The following is a description of a gene set: Human Gene Set: ZSCAN31_TARGET_GENES studied in species Homo sapiens Genes containing one or more binding sites for (ZSCAN31) in their promoter regions (TSS -1000,+100 bp) as identified by GTRD version 20.06 ChIP-seq harmonization. from publication Yevshin I, Sharipov R, Kolmykov S, Kondrakhin Y, Kolpakov F (PMID 30445619), and this is the list of marker genes: ERVK3-1, NSMCE4A, COPA, GNL3L, APIP, ANKRD42-DT, ZNF334, MAST2, TSNAX-DISC1, HTR7P1, TRIM8-DT, DNAJC25, LSR, NUP160, CCDC69, RSRC1, GIN1, BANP, GPAM, OVCA2, HILPDA-AS1, VPS51 (NCBI Gene Id 739), NUP107, RTTN, CCND2, EAF1, MRPS31, RNF122, SAMD11, ENTREP3, TAF12-DT, ZNF428, TRAF3IP1, RCAN2-DT, GRK4, BMF, TNFRSF19, CFAP74, KLHL20, CUL5, DYNC2I1, ARHGEF25, DNAJB1, GGA1, NUDT19-DT, TTBK1, SRSF2, SLX9, NBPF1, AFF4, TRMU, ITPR2, GMNN, DNAI4, UBIAD1, KAT6A, ZNF565 (zinc finger protein 565), AURKAIP1, GTF2H2C, ARPIN, SNORA8, PSTK, DUS1L, VTA1, RPS18, LINC03060, SUOX, ZAR1L, UBXN1, PHB1, KIF1C (kinesin family member 1C), NUBPL-DT, ASNS, SMIM27, PMAIP1, GNAI3, SKP2, MTFR1, SCAND3, PAK2, AMDHD1, MRPL40, NUDT19, POLR3B, B9D1, USP44, LINC02086, LRRC37A5P, WDR11-DT, DDX55, PDXDC2P, SLC25A10, SLC27A3, SUPT5H, CAST, MIR3661, PFKM, ARHGDIA, RPIA, AP3B1 (adaptor related protein complex 3 subunit beta 1), PIERCE1, AARSD1, OAZ3, NDUFAF4P1, HMOX2, ADAT2, VPS13B, LINC01098, TACO1, RCAN1, MAN2C1, COPS7B, ABCA17P, ERRFI1-DT, PIN4, REXO4, CSRNP2 (cysteine and serine rich nuclear protein 2), SRRM2-AS1 (SRRM2 antisense RNA 1), PGAM5, TRIM8, TSNAX, CCDC59, TTC23L, PPP2CA, BAZ1A-AS1, KLHL42, CAPN14, EEF1A1, NUP107-DT, NAPG, ZNF829, GIPC1, COA6-AS1, ZNF511-PRAP1, RUSF1-DT, MYO10, GOLM2, POLG, E2F4, KIF23-AS1, CDKN2C, TIGD1, ABR (NCBI Gene Id 82701), METTL6, MLEC, SPOPL, PAM16, SFT2D3, EFCAB10, TMEM147, LINC00665, PPP6R2, PGAM1P5, HNRNPL, PDE4A, SNRNP25, RFX2, ETNK1, STX6, MRPS31P4, NIPBL, CCNT1, ELP3, TACC2, SNX17, TMEM116, CCNC, PEX13, PNRC1, SLC24A1, ELL3, PDCD6P1, LARP6, STX18, UBXN2A, PAFAH1B3, DSTYK, METTL25, CNPY3, ZDHHC17, RNPEP, WDR90, PHKG2, TLL2, NPPC, EXOSC9, MCRS1, FBXW4, KIAA0319L, ZSCAN18, HSPA4, WTAP, KCNS3, MIPEP, PRDX2, COA6, INPP5B-AS1 (NCBI Gene Id 128266844), ANKFY1, AMACR, THAP1, SNRPD1, TMEM222 (transmembrane protein 222), ARID1A, RBBP5 (RB binding protein 5, histone lysine methyltransferase complex subunit), MYO9A, VPS33B-DT, KCTD7, IGHMBP2, RRP15, RAB40A, DENR, PRKAA1, PURA, ZNF721, BMS1P4-AGAP5, LRFN2, HDAC5, TMEM79, CZIB, ZNF487, ZMPSTE24, TMEM202-AS1, YIPF2, COPRS, GRB2, CADM1, NDP-AS1, DOC2A, MTF2, MTR, KCNJ2, ZMPSTE24-DT, ZNF529-AS1, NCOA4, LYRM7, HSPA5-DT, SNORA1, LBX1, ARPIN-AP3S2, ADD3-AS1, TRDMT1, USP30, PPIP5K2, DHRS4-AS1, PGM3, SLU7, STARD10, LGALS1, MRPL19, SLC25A48, C8orf88, MIR1302-3, ZNF180, LUZP1, CLK3, IBA57-DT, PRRG2 (NCBI Gene Id 5639), TMEM14A, WDR11, EXOSC6, RFNG, CES2, NCDN, BRD8, TMEM147-AS1, PLPP6, RWDD2A, ZNF544 (zinc finger protein 544), TXNDC9, SMARCC1, G6PD, MFSD6, ENO1-AS1, CCPG1, AIRIM, ESYT1, PHPT1, IFT56, ZNF490, TBCB, BACH2, EMG1, FAM98C, RAI14, INTS12, MKX, FANCD2, ADD3, TRMT61B, PEX16, ENPP4, GUSBP2, NDUFC2, HERPUD1, ZNF263, SPEN, WSCD1, C10orf143, GNPAT, LRRC49, ABCA3, RBM45, NSFL1C, USPL1, CFAP298-TCP10L, PDLIM5, UBR3, PKN2, PFKFB3-AS1, PHB2, PPP1R12C, PDXK, COPS2, UBE2V1P4, COX4I1, RPS19BP1, PDE6D, ZNF425, HIRA, MBOAT1, INO80C (INO80 complex subunit C), SLC44A1, DNM1L, DMAP1, STRA6, DNA2, C19orf12, KLRG2, MCFD2, VPS36, SUSD4, EFCAB7, INCA1, PLCD3, R3HCC1, ERMARD, CSTF2T, PDXDC1, HTR5A, DRG2, TLN1, MED25, RTKN2, SNORD6, MIR4519, LNPEP, PCBD2, PCLAF, CZIB-DT, PPP1R12B, SGK1, LIN9, PPP6R1, TXNDC12, GBA1, NT5DC3, GLIS2, CDKL2, TUBA1A, ENSG00000232995, ERP29, SDHAP3, PIGG, SNX24, ANKMY2, LINC02846, IPP (NCBI Gene Id 3652), DYNLT2, CCDC87, CABLES2, MRPL9, LINC02987, ZKSCAN2, HERC3, FEM1B, BTF3L4, SEC11A, PIP5K1B, EXOSC3, DNAJC25-GNG10, HMGB1, ETNK1-DT, CCDC38, MTF1, ZNF420, HNRNPA0, NOL9, CUL7, ANGEL1, FAAP24, RNF144B, DNAH2, ZBTB45, ATOSA (atos homolog A), PPAN (NCBI Gene Id 84997), STN1, ZNF566, MAST4, C18orf21P1, HINT3, LATS1, LINC00240, SUB1, MANEAL, EEFSEC, ENHO, TTC4, ZNF527, NDUFC2-KCTD14, FBXW11, KLHDC9, PNRC2, PRR3, ZNF747-DT, CHD9, UGCG, FZD2, BPTF, POLG-DT, IDI1, MRM2, VPS33B, LINC01547, PDE11A, MRPL58, TMEM101, CENPP, LINC02292, DCAF6, ZNF607, SRSF11, MEAK7, MTERF2 (mitochondrial transcription termination factor 2), UBE2D2, ZNF460, AKT3, ACBD6, SPHK1, TOLLIP, SLC35E1, ARHGAP45, LINC02593, C17orf75, FUZ, FOXN2, EIF5B, PHAX, ZNF260, COASY, LZTS2, RARA, SF3A3, RBM48, EME1, POU2F2, VGLL4, TAF12 (TATA-box binding protein associated factor 12), NRSN2, GPR89A, BMAL2, NAPEPLD, MOB4, PTPN20, MEMO1, FBXO4, ZNF284, CCDC77 (NCBI Gene Id 84318), KCTD13-DT, CPSF4, RMDN3, MAPK14, ENPP3, ZBED6, TDP2, RNVU1-27, CLTC, PSME3, TOLLIP-DT, NOXA1, PEX14, CFAP298, ITGB3BP, ERMP1, TAS1R1, HMGA2-AS1, ZNF461, NMNAT1, DLD, NDUFV3, ARMC2, H2BC26, ACSF2, SLC25A13, TRIP4, ETV6, REXO5, C18orf32, BRF2, ZNF223, TMED4, CMTM3, FAM133B, MYG1, NRP2, COMMD4, SYNGR2, H3-3B, EMC8, NUBPL, CAMLG, MED18, ISG20, MRS2, BMS1P4, SPTBN1, LINC00662, NIF3L1, FGFBP3, RUSF1, PTTG1 (NCBI Gene Id 9232), EHD3, PPP2CA-DT, TM2D1, SMIM8, NSL1, BBS4, SLC5A6, MAP3K21, OSBPL8, LINC01686, FNDC1-AS1, H3-3A, SLC27A5 (NCBI Gene Id 22942), CSNK2A1, MARVELD2, NDUFS7, PTDSS2, YTHDF2, ORC3, SESN2, STARD3, SOCS2, PACERR, PTPN9, CYREN, ENSG00000233461, ZNF107, ZMAT3, NOL8, NFYC, KIF23, KDM1A, KBTBD4, PPIL3, ARAP1, ZBED9-AS1, CARMIL1, GABARAPL2, PDCD2L, ACOT13, ZNF146, NOSIP, LZIC, PPAN-P2RY11, FAM98B, ENSG00000273145, CLTB (clathrin light chain B), NOP14, ALKBH3, ZNF793, ZNF511, GGT1 (gamma-glutamyltransferase 1), GALK2 (NCBI Gene Id 2585), VANGL2, BBS10, KDM5A, TNRC6A, CHD2, ELAC1, RARS2, MRPL44, PDCD5, GTPBP3, EIF1, TATDN3, MTOR, RPS7, TESHL, SETD5, GPR108, ZNF568, MIR6853, PEMT, DPP9, CAPN2, PROCA1, EIF2B4, UBE2I, NDUFAB1, DCTN2, RERE, HOXC4, ANKRD7, RNASEH2C, ADRM1, VCF2, ZER1, ANKRD42, CIDECP1, NDUFA11, INTS14, EIF2D, IMPACT, MAP2K5, RAB11A, SRP68, GLUD1P3, CCS, COPZ1, NDUFS3, LMBRD2, MTCO3P12, DNAH14, TTC23L-AS1, TANC1, NUF2, USP33, NUDT1, MANSC1, UCKL1, MIR3621, SPOPL-DT, TAF1D, SNRPB, RCAN2, SNHG5, ERI2, MPPED2, PTGS2, CFAP418-AS1, HADH, STK11, RBFOX3, IER5, RPL37, KCTD5, ERRFI1, ZMYM1, CAPNS1, IMP3, FSTL3, SNRNP200, PTCD1, ANO8, TRAPPC3, SLTM, PRKCSH, ZC3H11A, ENSG00000236846, POLR3K, CDIPTOSP, HDAC2, CALM1, METTL15, POLR2I, TMEM209, USP14, NME1-NME2, NT5C, SLC50A1, ADAM17, PPIL4, HEATR1, SLC39A7, ZDHHC4, TECR, ZC3H10, VPS26C, CDK2AP2, RAB23, ZNF780A, HMGN1, ZNF529 (NCBI Gene Id 92279), ZNF689 (NCBI Gene Id 553125), CLN3, EIF4E2, MYO3B-AS1, ZNF566-AS1, MIR6781, PRPF40B, CDIPT, AGAP3, USP22, DAZAP1, CSK, ZC3H15, GATAD1, ME2, MRPS2, SATB2, GFRA1 (GDNF family receptor alpha 1), TNFAIP8L1, DPY19L4, RPSAP69, CBLN3, SFR1, LTBP4, NABP2, LRRC40, SDHAF3, ODAD3, ZNF383, HILPDA, MRPS34, MRPL27, CCDC30, PEX3, CLPB, LOXL1-AS1, MTMR9, RN7SL521P, HDAC2-AS2, HCP5, PRSS27, MAP2K5-DT, FBXO22, AFF4-DT, NCSTN, RHOB, JMJD4, C15orf40, LINC02773, MCRIP2, BZW2, EXD3, C1orf131, MITD1, MPC2 (mitochondrial pyruvate carrier 2), ATRAID, ZNF747, TUBGCP3, C2CD2L, RPL27 (ribosomal protein L27), WRAP73, NKAPP1, RABEPK, DENND4A, HUNK, ZNF793-AS1, ZNF155, NOP16, CBX5, RPS4X, TARS2, MAP7D1, TMEM42, RPL13A, ADAP2, MIR762HG, ZNF195 (NCBI Gene Id 7748), HEATR5A, HEBP1, GINS3, CREB3, RGS5, FBXO5, MRPS23, PUS10, ASH1L, PNRC1-DT, SIRT5, GAP43, KCTD13, CSNK1E, IQGAP2, MYOCD, KIF20A, LLGL2, C12orf76, DPAGT1, SMG5, BAG3, MKRN2, TMEM186, PRRT3-AS1, MST1P2, GSTCD, CFAP20DC, IPO4, FBXO27, USP31, TMEM50B, RBPMS, SCAF4, ZSCAN31, PFKFB3, GOLPH3L, THAP10, MRPL30, NMRAL1, NUDT5, TVP23B, SURF6, LRP6 (LDL receptor related protein 6), TATDN2, ASAH2B (NCBI Gene Id 653308), FGF9, PGGT1B, TRAM2, TMEM242, TLCD2, RN7SL2, VPS25, PDXDC2P-NPIPB14P, ZSCAN25, ATF7IP2, CDK5RAP1, TIMM29, SPATA20, WDR38, MFSD11, HOXA11-AS, PAXBP1, LINC03014, TIMM13, CHST8, MIR4692, MNAT1, S100A1, TRAM2-AS1, JPX, SMAD5, DALRD3, VPS13B-DT, SRSF5, HEATR5A-DT, DDHD2, ANKRD18B, TBC1D19, SUMO1, SNAP47, PSMA6, CDC123, MBNL1, ADGRV1, FUT8-AS1, C10orf88, ARRDC3, POLR3C, ZNF783, NME1, NHSL1, IMMT, STX18-AS1, MCFD2P1, CES3, RHOT2, CIAO2B, DAPK3, VANGL1, ELOC, TMEM106C, CDC7, MCM3AP, ZNF792 (NCBI Gene Id 126375), ITGA2, CYSRT1, SAR1B, GXYLT1, EIF4A2, EGFLAM, GNL1, STXBP5, EPCIP-AS1 (NCBI Gene Id 54067), TEFM, NBPF25P, EDEM2, ZNF398, H2BC5 (NCBI Gene Id 3017), HIBCH, ZNF564 (NCBI Gene Id 163050), SRRM2, RHBDF1, C18orf54, BRCA2, MCC, MED23, TUBA1C, LINC01023, USHBP1, TMED2, KHNYN, TOR1AIP1, MRPL1, PCBP1-AS1, DPYSL3, ADPRS, ZNF791, SORBS2, WDR37, CMKLR1, COMMD9, RALA, RNF115, H3-3A-DT, PMM2, CROCCP2, WDR24, BCAP29, ZNF382, YBEY, EID2B, LINC02613, MDN1, ZFP62, BECN1, GPD1L, CIC, FAM47E, HIGD2B, TMEM242-DT, CKS2, CCAR2 (cell cycle and apoptosis regulator 2), VPS52, ATR, ZNF790, ITGA3, ATAD2B, ARMH3, EIF3A, NR1H2, SCNN1G, S100A13, FAM47E-STBD1, LINC03067, CHD3, STARD6, LINC01990, ZNF302 (zinc finger protein 302), PIERCE2, GABRB1, LINC00205, MRPL21, RNU6-194P, EME2, ACTN4